The following is a description of a gene set: Any process that results in a change in the behavior of an organism as a result of a cocaine stimulus. species: Homo sapiens Human Gene Set: GOBP_BEHAVIORAL_RESPONSE_TO_COCAINE, and this is the list of marker genes: DRD4, DRD3, HTR2A, SDK1, HOMER2, FADD, OPRK1, DRD2, SLC6A4, CDK5, HOMER1, FOSB (NCBI Gene Id 2354), EHMT2, PPP1R1B, SNCA, DRD1